Given this list of marker genes TCF3, FLRT3, PIK3CG, ASXL1, TTC12 (NCBI Gene Id 54970), CHN2, UNC13B, CACNA1E, GRIA3, ARF3, NAP1L5, NOVA1, GRM8, PRR11, KIF1B, SCML1, PDLIM1, PDGFC, TLE4, USP32, E4F1, USH1G, NRP1, ABCC6, CNOT2, SH2D1A, KLF12, ZIC5, CREB5 (cAMP responsive element binding protein 5), OTOP2, TRIM69, SPACA6, CISH, HOXA3, ZFHX3, SATB1, HOXD9, KLF14, NOG, PIK3R1, NIPBL, DICER1, MGAT4C, OTX2, ZBTB18, KCNQ5, NEUROD4, ELF4 (NCBI Gene Id 2000), GBX2, SKA2, TFAP4, KLHL1, KIAA2013, ZMYND8, NCALD, VEGFD, CLPX, HJV, CACNB3, PHOX2B, GCNT2, TFAP2A, LUC7L3, LINC03124, ONECUT2, TSHZ2, GATM, BEND4, CCN4, ST13P4, FIGN (fidgetin, microtubule severing factor), STRN, HOXB7, PHF21B, ODF2, CDKN2C, PHF20L1, PRRT1, ZNF362, HS3ST3A1, SOX4, FBXO32, IGSF21, OTP, HLX, FRMD6, ESRRG, CHODL, FAM91A1, ANKS1B, PPP1R10, NDST3, ADGRL2, ELAVL4, HCFC2, ADCY8, RBBP8NL, ANKRD12, MRPS18B, HRK, KLHL4, NECAP1, SYNPO2L, SAMD11, EDN1, TCF7L1, TPM2, IRX3, JARID2, NFATC4, FEZF2, CNTNAP5, B3GAT3, TAGLN3, LHX9, NRAP, GPR22, HOXC5, LINC01597, SPEM1, LINC01567, SOST, here is a description of the gene set: Genes having at least one occurrence of the motif TGACAGKTTTAYGA in the regions spanning 4 kb centered on their transcription starting sites. This matches the MEIS1, HOXA9 transcription factor binding site V$MEIS1AHOXA9_01 (v7.4 TRANSFAC). studied in species Homo sapiens Human Gene Set: MEIS1AHOXA9_01